The following is a description of a gene set: Any process that modulates the rate, frequency or extent of glomerulus development, the progression of the glomerulus over time from its initial formation until its mature state. The glomerulus is a capillary tuft surrounded by Bowman's capsule in nephrons of the vertebrate kidney. studied in species Mus musculus Mouse Gene Set: GOBP_REGULATION_OF_GLOMERULUS_DEVELOPMENT, and this is the list of marker genes: Ret, Bmp4, Agtr2, Pax2, Ppp3ca, Nog